Given this list of marker genes Calcrl, Adipoq, Ercc1, Naglu, Gria1, Oxt, Khk, here is a description of the gene set: Any process that results in a change in state or activity of a cell or an organism (in terms of movement, secretion, enzyme production, gene expression, etc.) as a result of a disaccharide stimulus. species: Mus musculus Mouse Gene Set: GOBP_RESPONSE_TO_DISACCHARIDE